The following is a description of a gene set: Neighborhood of EI24 etoposide induced 2.4 mRNA in the MORF expression compendium Neighborhood of EI24 Human Gene Set: MORF_EI24 species: Homo sapiens, and this is the list of marker genes: LSM4, TMED9, ALG3, GNB1, EI24, GTF2A2, CSNK2B, MLEC, MTREX, NCBP2, BUB1, FH, MRPS18B, FAM120A (family with sequence similarity 120 member A), METAP1, SCARB1, TRAPPC3, TCEA1, NUP62, MFAP1, STK24, IARS1, XPOT, RNPEP, UBE2S, SERP1, NSDHL, CS, ABCF1, NAA10, ATXN10, SSB, RTN4, DDX19B, RAD23A, TM9SF2, VPS26A, HCCS, TUFM, GANAB, SRSF1, VBP1, XPO7, EPRS1, RAC1, HDAC2, GARS1, CCT3, AARS1, TM9SF4, BUB3, AHSA1, PPM1G (protein phosphatase, Mg2+/Mn2+ dependent 1G), VDAC2, HNRNPAB, COQ9, PDHB, CCT5, YARS1, SSBP1, POLR2I, TOMM70, RFC4, ATP5PF, MCFD2, NCOR2, SNRNP200, SEC24C, TARS1, VDAC1, CYCS, LARP1 (La ribonucleoprotein 1, translational regulator), HSPE1 (heat shock protein family E (Hsp10) member 1), ATP5MC3, BAZ1B, MTCP1, DYNLL1, ACTL6A, DGUOK, H2AZ1, HAT1, EIF2S2, VDAC3, NDUFV1, IFRD1, SART3, EIF4G1, GLO1, NDUFS2, SDHB, PTGES3 (prostaglandin E synthase 3), SOD1 (NCBI Gene Id 6647), IDH3G, PPT1, ESD, ALG8, MDH1, PRDX4, KHSRP, PRKDC, LYPLA1, NUDC, LSM2, DNAJC11, NDUFC1, KXD1, SLC3A2, MARS1, IMMT, TMEM106C, PRPS2, SNRPA, ATP5PO, DEXI, AP2S1, NDUFB3 (NCBI Gene Id 4709), G3BP2, ZNRD2, GOT2, AKR7A2, SLC1A5, CCNB1, HNRNPA2B1, TRIP13, ZWINT, PRDX3, IPO7, STARD7, GLB1, HAX1, AFG3L2, GNG5, BCAP31, DOCK3, RHEB, F8A1, PSMB2, RUVBL2, CALM3, HDDC2, SDHA, DKC1, SSRP1